The following is a description of a gene set: Epidermal nevus studied in species Homo sapiens Epidermal naevi are due to an overgrowth of the epidermis and may be present at birth (50%) or develop during childhood. Human Gene Set: HP_EPIDERMAL_NEVUS, and this is the list of marker genes: XPA, NSDHL, BRAF, AKT1 (NCBI Gene Id 207), KRAS (KRAS proto-oncogene, GTPase), LEMD3, NRAS, NEK9, SMO, PIK3CA, PTEN, HRAS